Given this list of marker genes ATP6V0D1, CKB, HDAC9, ARL8B, SERP1, CD300LF, IDH1, FXYD5, TGFB3, LEPROT (NCBI Gene Id 83080), LAG3, PDPN, GUSB, LMAN1, SPP1, NPC2, MRPL11, P2RX4, UBL3, ALCAM, NUDT2, ITGAV, SLC38A6, HMOX1, LRP1, CRYZL1, DYNLT3, MS4A4A, EEA1, TMCC3, APOC1, PRSS46P, NRP2, LAMP2, CGRRF1, RBM47, ATP6AP2, GAB2, ITGAM, ATP8A1, PHYH, SLC29A3, ATP5IF1, PDE7B, SLC31A2 (NCBI Gene Id 1318), MRC1, LRRC58, DCXR (dicarbonyl and L-xylulose reductase), SAMSN1, INTS12, ADAM17, PRF1, TREM2, RAP2A (NCBI Gene Id 5911), MCFD2, OLFML3, B4GALT6, DCLRE1C, PLXNA1, PROS1, NCEH1, PLEKHB2, MSRB1, BASP1, FUCA1, ATP6V1G1, UBC, TENT5C, LMBRD2, STAB1, SLCO2B1 (NCBI Gene Id 11309), SBF2, SDCBP, SKAP2, JUN, IFITM1, ANXA3, CTSA, FABP7, SEMA4D, ZNG1A, PPHLN1, GLRX, NDEL1, FGL2, PTGS1, THEMIS2, VPS35, STOM, CPNE2, RGS1, SLC15A3, SCAMP2, EHD4, SRGAP2, FNDC3A, TRAPPC2L, IL5, RNF103, CALM3, SNX30, TNFRSF4, TMBIM4, CEP170, MAP4K3, TBXAS1, PDGFA, PLK3, DOCK4, TMEM86A, DST, CABYR (NCBI Gene Id 85304), TPST1, CSF1, DUSP6, TLR3, CD86, FABP4, GTF2H2, FMNL2, TIMP2, LYN, TLR7, CFLAR, DAB2 (NCBI Gene Id 1601), BCL2L1, SLC43A2, PLEKHO2, LIPA, CSF3R, MMP8, IFT22, GPD2, FBLIM1, CD68, HSF2, RAB14, NAV3, SNX13, ITGB2, SCAMP1, HTR2B, DUSP16, CAPZB, MAFG, ATP6V1E1, ACER3, CTNNA1, PTK2B, TRAPPC2, SNX5, PPP1R7, CCL7, CD33, PLEK, PLAU, MPI, CHMP5, SNX29, EFHD2, PLXNB2, FRRS1, SPTLC2, IL18, ID2, EXTL3, LAMP1, HLX, UBASH3B, SEPTIN2, SNAP23, IL10, TMEM176A, TGS1 (trimethylguanosine synthase 1), MMP27, here is a description of the gene set: IFNs are highly pleiotropic cytokines also endowed with marked anti-angiogenic activity. In this study, the mRNA expression profiles of endothelial cells (EC) exposed in vitro to IFN-alpha, IFN-beta, or IFN-gamma were determined. We found that in HUVEC as well as in other EC types genes were upregulated (>2-fold increase) by IFNs, including genes involved in the host response to RNA viruses, inflammation, and apoptosis. Interestingly, genes showed a >5-fold higher induction by IFN-alpha in EC compared to human fibroblasts; among them, the gene encoding the angiostatic chemokine CXCL11 was selectively induced by IFN-alpha in EC along with other genes associated with angiogenesis regulation, including CXCL10, TRAIL, and guanylate binding protein 1 (GBP-1). These transcriptional changes were confirmed and extended by quantitative PCR analysis and ELISA; whereas IFN-alpha and IFN-beta exerted virtually identical effects on transcriptome modulation, a differential gene regulation by type I and type II IFN emerged, especially as far as quantitative aspects were concerned. In vivo, IFN-alpha-producing tumors over-expressed murine CXCL10-11, GBP-1 and TRAIL, with evidence of CXCL11 production by tumor-associated EC. Overall, these findings improve our understanding of the anti-angiogenic effects of IFNs by showing that these cytokines trigger an anti-angiogenic transcriptional program in EC. Moreover, we suggest that quantitative differences in the magnitude of the transcriptional activation of IFNresponsive genes could form the basis for cell-specific transcriptional signatures. Genes up-regulated in ndothelial cells: untreated versus interferon alpha. Human Gene Set: GSE3920_UNTREATED_VS_IFNA_TREATED_ENDOTHELIAL_CELL_UP from publication Indraccolo S, Pfeffer U, Minuzzo S, Esposito G, Roni V, Mandruzzato S, Ferrari N, Anfosso L, Dell'Eva R, Noonan DM, Chieco-Bianchi L, Albini A, Amadori A (PMID 17202376) species: Homo sapiens